Given this list of marker genes Pik3c2a, Synj2, Pip5k1a, Pip4k2c, Inpp5j, Mtmr14, Pik3r2, Inppl1, Pik3c2b, Pip5k1c, Ocrl, Rab4a, Mtmr1, Pik3r5, Mtmr9 (myotubularin related protein 9), Pik3cb, Mtmr3, Arf1, Ptpn13, Mtmr6, Plekha3, Plekha8, Inpp4b, Pi4k2a (phosphatidylinositol 4-kinase type 2 alpha), here is a description of the gene set: Reactome Pathway: Synthesis of PIPs at the plasma membrane part of: PI Metabolism electronically inferred by orthology from the curated human pathway species: Mus musculus This event has been computationally inferred from an event that has been demonstrated in another species.<p>The inference is based on the homology mapping from PANTHER. Briefly, reactions for which all involved PhysicalEntities (in input, output and catalyst) have a mapped orthologue/paralogue (for complexes at least 75% of components must have a mapping) are inferred to the other species.